The following is a description of a gene set: studied in species Homo sapiens Human Gene Set: GOBP_UDP_N_ACETYLGLUCOSAMINE_METABOLIC_PROCESS The chemical reactions and pathways involving UDP-N-acetylglucosamine, a substance composed of N-acetylglucosamine, a common structural unit of oligosaccharides, in glycosidic linkage with uridine diphosphate., and this is the list of marker genes: MGAT1, SLC35A3, GNPNAT1 (NCBI Gene Id 64841), NAGK, GNE, GNPDA2, GNPDA1, AMDHD2, B4GALNT2, PGM3, UAP1L1, GFPT2, UAP1, GFPT1